Given this list of marker genes CCNA2 (NCBI Gene Id 890), E2F3 (E2F transcription factor 3), E2F2, CCNA1, RB1, CDK2, E2F1, CCNE1, CCNE2, here is a description of the gene set: EBV EBNA3C to p27-Cell cycle G1/S. Pathway ID: N00482. Pathway type: Pathogen. Pathway class: nt06165 Epstein-Barr virus (EBV). studied in species Homo sapiens Pathway Definition from KEGG: EBNA3C -> ((CCNA,CCNE)+CDK2) -> RB1 // E2F Human Gene Set: KEGG_MEDICUS_PATHOGEN_EBV_EBNA3C_TO_P27_CELL_CYCLE_G1_S_N00482